Given this list of marker genes DSTN, MYO1E, MYH9, VCL, CAPZA2, GABARAPL2, SPTBN1, FLNA, SYN1, TMSB4Y, PLS3, ACTN4, SPTAN1, LMOD1 (NCBI Gene Id 25802), FLII, CORO1A, CALD1, TWF1, ENC1, CFL1, PIP, FLNB, CNN3, MYH11, WDR1, FLNC, CNN2, MARCKS (myristoylated alanine rich protein kinase C substrate), TPM4, STMN2, MACF1, GSN, SVIL, CAPG, here is a description of the gene set: Genes in the cancer module 419. species: Homo sapiens Human Gene Set: MODULE_419